The following is a description of a gene set: part of: SLC-mediated transport of inorganic anions studied in species Homo sapiens Five human SLC13 genes encode sodium-coupled sulphate, di- and tri-carboxylate transporters located on the plasma membrane. Two transporters (NaS1 and NaS2) co-transport sulphate with sodium. The other members (NaDC1, NaDC3, and NaCT) co-transport sodium with di- and tri-carboxylates such as succinate, citrate and alpha-ketoglutarate (Pajor AM, 2006). Reactome Pathway: Sodium-coupled sulphate, di- and tri-carboxylate transporters, and this is the list of marker genes: SLC13A1, SLC13A4